Given this list of marker genes CASP8, MIR103A1, CYLD, RIPK1, MIR101-1, PELI1, SLC25A4 (solute carrier family 25 member 4), RBCK1, MIR485, FZD9, MIR22, MIR107, TP53, ASAH1, ITCH, RNF31, MIR223, YBX3, AIFM1, PRKN, CFLAR, PARP1, FADD, ZBP1, CAV1, MUTYH, OGT, SPATA2, ADPRS, CASP6, BIRC2, ARHGEF2, NOL3, RIPK3, NUPR1, MIR92A1, MIR221, BIRC3, BOK, MIR214, TSPO, here is a description of the gene set: Human Gene Set: GOBP_REGULATION_OF_PROGRAMMED_NECROTIC_CELL_DEATH Any process that modulates the frequency, rate or extent of programmed necrotic cell death. species: Homo sapiens